Given this list of marker genes ITPKA, PPIP5K2, MIOX, PPIP5K1, SLC5A3, MECP2, IMPA2, ISYNA1, IMPA1, here is a description of the gene set: The chemical reactions and pathways involving inositol, 1,2,3,4,5,6-cyclohexanehexol, a growth factor for animals and microorganisms. Human Gene Set: GOBP_INOSITOL_METABOLIC_PROCESS species: Homo sapiens